The following is a description of a gene set: Prolonged ERK activation events studied in species Homo sapiens Human Gene Set: REACTOME_PROLONGED_ERK_ACTIVATION_EVENTS, and this is the list of marker genes: RAP1A, NTRK1, KIDINS220, CRK, MAP2K1, BRAF, CRKL, RAPGEF1, FRS2, MAPK3, MAP2K2, MAPK1, YWHAB, NGF